The following is a description of a gene set: Mouse Gene Set: GOBP_NEGATIVE_REGULATION_OF_DELAYED_RECTIFIER_POTASSIUM_CHANNEL_ACTIVITY Any process that stops, prevents or reduces the frequency, rate or extent of delayed rectifier potassium channel activity. studied in species Mus musculus, and this is the list of marker genes: Ank3, Kcne2, Kcnrg, Kcne1, Sumo1, Kcnq1, Kcne3